The following is a description of a gene set: Mouse Gene Set: GOBP_NUCLEAR_TRANSPORT species: Mus musculus The directed movement of substances into, out of, or within the nucleus., and this is the list of marker genes: Bcl3, Nup133 (nucleoporin 133), Nup160, Ptpn11, Cwh43, Hspa8, Hspa12a, Chtop, Ythdc1, Rbm22, Alyreffm3, Prkag1, Ppp3r1, Ifng, Alyreffm4, Cdkn1a, Ipo7, Chp2, Sqstm1, Akirin2, Kpna7, Ptpn22, Nup50l, Eif6, Ranbp3l, Agtr2 (NCBI Gene Id 11609), Pom121, Lzts2, Alyreffm7, Rapgef3, Alyreffm2, Pkia, Pttg1ip, Sfn, Rasl2-9, Nup214, Poldip3, Alyreffm8, Wnk1, Mdfic, Nxt1, Nolc1, Ep300, Gas6, Chchd4, Snupn, Alyreffm10, Kcnq3, Brca1, Ppp3ca (protein phosphatase 3, catalytic subunit, alpha isoform), Inpp4b, Ran, Eif4enif1, Akap13, Cd36, Hsp90ab1, Ctdspl2, Bmal1, Zc3h12a, Nup35, Hyal2, Tmem53 (NCBI Gene Id 76384), Nr4a1, Hspa9, Nup155, Mlx, Rae1, Nup42, Thoc5 (THO complex 5), Nutf2-ps2, Spg11, Ing1 (inhibitor of growth family, member 1), Elavl1, Cabp1, Axin1, Dmap1, Sem1 (SEM1, 26S proteasome complex subunit), Nedd4 (NCBI Gene Id 639396), Tardbp, Ranbp2 (NCBI Gene Id 353053), Tsc1, Nop9, Ifi27, Nfatc3, Iws1, Tgfb1, Mapk1, Atf2, Pcid2, Bmpr1a, Frat1, Nup188, Frat2, Nutf2, Notch1, Kpna2, Bmpr2, Cchcr1, Fbxo22, Nxf7, Ddx39a, Traf3ip2, Ipo5 (NCBI Gene Id 97586), Ubr5, 1700009N14Rik, Jup, Lsg1, Sec13, Pik3r2, Lrrk2 (leucine-rich repeat kinase 2), Pola2, Pkig, Tsc2, Riok2, Txn1, Pml, Rps15, Cdkn2a, Adam10, Mcm3ap, Phb2, Ect2, Eny2, Xpo7, Fermt1, Abra, Nup210, Pttg1ip2, Tnpo1, Calr, Ddx19a, Kpna4, Prkcq, Alyreffm6, Thoc3 (NCBI Gene Id 73666), Nsun2, Nup50, Nfkbia, Nup153, Mapk14 (mitogen-activated protein kinase 14), Gbp4, Ptpn14, Atxn1, Nrde2 (nrde-2 necessary for RNA interference, domain containing), Stat3 (NCBI Gene Id 68733), Appl1, Camk1, Fchsd1, Trp53, Ipo9, Prpf4b, Ranbp17, Ltv1, Cry2, Hsp90aa1, Rbm10, Epm2a, Ankle1, Xpo1, Hnf4a, Ptgs2, Bmp4, Cited1, Egr2, Chp1, Rangrf, Pabpn1, Ddx39b, Camk4, Ppm1a, Ddx25, Stk4, Bach2, Ankrd54, Stk3, Nxf2, Akap5, Aaas, Efcab7, Zfp384, Akt1, Nxt2, Fam53a, Cdan1, Ncbp1 (NCBI Gene Id 60346), Sirt7, Alyreffm11, Sirt6, Nos3, Nemf, Ier3, Ywhab, Smo, Alyref, Flna, Sdad1, Nup107, Kpna1, Desi1, Ncbp2, Gckr, Cfl1, Lmna, Ranbp6, Rpain, Ufm1, Kpna6, Tnfrsf1a, Supt6, Eif4e, Xpot, Ddx5, Kpna3, Zpr1, Fgf9, Ahctf1, Alkbh5, Malt1 (NCBI Gene Id 240354, MALT1 paracaspase), Gsk3b, Six2, Cdh1, Cdkn1b, Rgs14, Neurod1, Nxf1, Tnpo2, Uhmk1, Cpsf6, Smurf1, Psen1, Nup62cl, Tek, Xpo6, Zc3h11a, Pkd1, Akap1, Hhex, Kpna2rt, Ahcyl1, Hm629797, Peg12, Pik3r1, Htatip2, Fam76b, Wipf1 (WAS/WASL interacting protein family, member 1), Emd, E2f3, Ncbp3 (NCBI Gene Id 97706), Nf1, Ppp1cc, Nmd3, Seh1l, Alyref2, Med1, Kpnb1, Hnrnpa2b1, Ssb, Anp32b, Thoc7, Park7, Nup88, Xpo5, Zic1, Hnrnpa1, Alyreffm5 (NCBI Gene Id 214151), Khdrbs1, Cse1l, Mavs, Ube2i, Nup85, Rbm8a, Eif4a3, Ptpn5, Tnpo3, Sumo1 (small ubiquitin-like modifier 1), Gli3, Thoc6, Rbm33, Hikeshi, Mdn1, Tpr, Shh, Anp32a, Il6, Nxf3, Phax (NCBI Gene Id 72695), Gper1 (NCBI Gene Id 76854), Sarnp, Ipo13, Nup93, Ddx19b, Rita1, Thoc2l, Syk, Nol6, Rbm4, Kcnq2, Prkcd, Nup43 (NCBI Gene Id 71809), Ywhae, Thoc1, Thoc2, Fam53b, Sprn, Bag3, Dhx9, Nup58, Rab18, Pom121l2, Akap8l (A kinase anchor protein 8-like), Rangap1, Fmr1, Ipo11, Nutf2-ps1, Agap3, Dyrk1a, Gle1, Bmp2 (NCBI Gene Id 98992), Anp32-ps, Adar, Cdk1, Prickle1, Apod, Alyreffm14, Trim28, Magoh, Casc3, Heatr3, Nup37, Rsrc1, Mmp12, Rbm15b, Magohb, Nup98, Nup54, Ppp1r12a, Tmco6, Cdk5, Bard1, Ipo8, Appl2, Hcls1, Alyreffm9, Hdac3, 1700017N19Rik, Fyttd1, Ranbp3, Lep, Xpo4, Npm1, Xbp1, Fam53c, Rab23, Stradb, Ndc1, Txnip, Drd1, Il33, Jak2, Agt, Strada, Setd2, Phip, Ipo4, Alyreffm1, Ei24, Mdm2, Mlxip, Prkaca (NCBI Gene Id 18747), Ranbp1, Srsf3, Six3, Nup62, Uaca, Angpt1, Prkd1, Sp100